Given this list of marker genes CLEC2B, WBP11, TNFRSF1A, ARHGDIB (NCBI Gene Id 397), EMP1, ETV6, ITFG2, C12orf57, TAPBPL, SLC2A3 (solute carrier family 2 member 3), CLEC7A, RECQL, A2M, MGP, PTMS, PHB2, CCND2, here is a description of the gene set: Human Gene Set: KORKOLA_TERATOMA_UP from publication Korkola JE, Houldsworth J, Chadalavada RS, Olshen AB, Dobrzynski D, Reuter VE, Bosl GJ, Chaganti RS (PMID 16424014) species: Homo sapiens Genes from the 12p region that up-regulated in teratoma cells compared to normal testis. Adult male germ cell tumors (GCTs) comprise distinct groups: seminomas and nonseminomas, which include pluripotent embryonal carcinomas as well as other histologic subtypes exhibiting various stages of differentiation. Almost all GCTs show 12p gain, but the target genes have not been clearly defined. To identify 12p target genes, we examined Affymetrix (Santa Clara, CA) U133A+B microarray ( approximately 83% coverage of 12p genes) expression profiles of 17 seminomas, 84 nonseminoma GCTs, and 5 normal testis samples. Seventy-three genes on 12p were significantly overexpressed, including GLUT3 and REA (overexpressed in all GCTs) and CCND2 and FLJ22028 (overexpressed in all GCTs, except choriocarcinomas). We characterized a 200-kb gene cluster at 12p13.31 that exhibited coordinated overexpression in embryonal carcinomas and seminomas, which included the known stem cell genes NANOG, STELLA, and GDF3 and two previously uncharacterized genes. A search for other coordinately regulated genomic clusters of stem cell genes did not reveal any genomic regions similar to that at 12p13.31. Comparison of embryonal carcinoma with seminomas revealed relative overexpression of several stem cell-associated genes in embryonal carcinoma, including several core stemness genes (EBAF, TDGF1, and SOX2) and several downstream targets of WNT, NODAL, and FGF signaling (FGF4, NODAL, and ZFP42). Our results indicate that 12p gain is a functionally relevant change leading to activation of proliferation and reestablishment/maintenance of stem cell function through activation of key stem cell genes. Furthermore, the differential expression of core stem cell genes may explain the differences in pluripotency between embryonal carcinomas and seminomas.